Given this list of marker genes Pth, Lep, Gnrh1, Gnao1, Jak2, Ghrh, Gphb5, Crh, Adcyap1, Nppa, Fyn, Ucn3 (NCBI Gene Id 83428), Ucn2, Gnas, Nppc, Nppb, Vip, Gh, Gria1, Psmc5, Jak1, Gpha2, Socs2, Ucn, Pthlh, Fabp4, Ptpn11, Jak3, Tyk2, here is a description of the gene set: Mouse Gene Set: GOMF_HORMONE_RECEPTOR_BINDING Binding to a receptor for a hormone. studied in species Mus musculus